Given this list of marker genes HDC, UROC1, CARNMT1, HAL, AMDHD1, FTCD, CARNS1, HNMT, here is a description of the gene set: The chemical reactions and pathways involving L-histidine, 2-amino-3-(1H-imidazol-4-yl)propanoic acid. Human Gene Set: GOBP_L_HISTIDINE_METABOLIC_PROCESS species: Homo sapiens